Given this list of marker genes OXTR, TRDN, KCNA1, CRYAB, TMSB4Y, GJA5, CACNG1, HRC (histidine rich calcium binding protein), CHRNB1, GNAO1, VIPR1, DSTN, FLII, GJA1, SSPN, CLCN1, CKMT2, ACTC1, CALD1, MYL3, GSN, RYR1, FKBP1B, PLN, NOS1, FXYD1, ACTA1, CXCL12, here is a description of the gene set: studied in species Homo sapiens Human Gene Set: MODULE_330 Genes in the cancer module 330.